Given this list of marker genes Zfp36, Creg1, Klf6, Hspa1b, Fosb, Atf3, Kmt2e, Pdpk1, Tsc22d3, Dusp1, Pabpc1, Hspa1a, Fos, Jun, Klf4, here is a description of the gene set: Cytokines mediate cell-cell communication in the immune system and represent important therapeutic targets. A myriad of studies have highlighted their central role in immune function, yet we lack a global view of the cellular responses of each immune cell type to each cytokine. To address this gap, the authors created the Immune Dictionary, a compendium of single-cell transcriptomic profiles of more than 17 immune cell types in response to each of 86 cytokines (>1,400 cytokine-cell type combinations) in mouse lymph nodes in vivo. A cytokine-centric view of the dictionary revealed that most cytokines induce highly cell-type-specific responses. For example, the inflammatory cytokine interleukin-1β induces distinct gene programmes in almost every cell type. A cell-type-centric view of the dictionary identified more than 66 cytokine-driven cellular polarization states across immune cell types, including previously uncharacterized states such as an interleukin-18-induced polyfunctional natural killer cell state. Genes negatively differentially expressed in cell type: cDC2 (conventional dendritic cell type 2) upon treatment with cytokine: IFN-ε in mouse lymph nodes in vivo. Mouse Gene Set: CUI_CDC2_IFNE_RESPONSE_DN from publication Cui A, Huang T, Li S, Ma A, Pérez JL, Sander C, Keskin DB, Wu CJ, Fraenkel E, Hacohen N (PMID 38057668) studied in species Mus musculus